The following is a description of a gene set: Human Gene Set: GSE36392_TYPE_2_MYELOID_VS_EOSINOPHIL_IL25_TREATED_LUNG_DN Many symptoms associated with allergic asthma result from the sequelae of type 2 inflammation. Interleukin (IL)-25 promotes type 2 inflammatory responses, and T2M cells represent an IL-4 and IL-13 producing granulocytic IL-25 responsive population. We used microarrays to characterize the gene expression profile of T2M cells, and compared T2M cells to other inflammatory subsets (eosinophils, neutrophils, and macrophages) in the lungs of mice with IL-25-induced pulmonary inflammation. from publication Petersen BC, Budelsky AL, Baptist AP, Schaller MA, Lukacs NW (PMID 22543263) species: Homo sapiens Genes down-regulated in comparison of type 2 myeloid (T2M) cells treated with IL25 versus eosinophils treated with IL25., and this is the list of marker genes: ANKRD37, GGT5, BMX, PDLIM5, DMBT1 (NCBI Gene Id 55583, deleted in malignant brain tumors 1), CNR2, PLA1A, LCN2, SP4, NT5E, TNRC6B, YPEL3, CLK1, GLRX, IL23A, GADD45B, MACROD2, ADGB (androglobin), MED14, ZNF473, CD274, ADTRP, UBE2H, NEK6, AMER2, C18orf32, SLC15A3, RLF, PIGV, PHF23, S100A8, MAPK13, UBA1, NLRP12, MUC16, IL1RAPL1, FMNL3, SOAT2, NXPE3, C15orf48, GMPR2, IRF9, NFIL3, ETS2, STAMBPL1, ENTPD1, MINDY3, GRIN3A, CD300C, GSPT2, LYPD6B, CPED1, SNX18, SLCO3A1, IL18RAP, PDE7B, HSH2D, CDS2, KCTD11, SNORD89, FBXO28, CDC42EP4, PICALM, ENTPD3, RNF135, NDEL1, KDM7A, CYP3A7, MIEN1, SLA, CXCL11, PIPOX, DYNLT2B, TNFSF14, GTF2E2, IFIT1B, HCAR2, CAPS2, DGAT2, ASTE1, HDC, HGSNAT, GSDME, ISG15, PTGER2, AGPAT2, SLC35A5, PLP2, DHX8, SEMA5B, SH2D5, CD300LD, RALGPS1, TNFRSF1B, HMGCL, SFXN5, ATG9A, LRRC3, LYRM4, SDR39U1, CLEC4D, SYCP2, IKBKE, TRMT1L, LRRC72, SAG, SVIP, SIRT2, CALHM6, SNX33, FKBP5, CDK17, MCL1, GK, GPCPD1, MED13L, IL12A, GPAT3, TUT7, HLA-DOB, PABIR1, HERC6, ITIH4, TMEM243, SUGT1, CACNA1E, KCTD8, G3BP2, CHAC1, HSD11B1, CARM1, PTPRC, PRPS1L1, JAK2, GAD1, SAXO4, PCBD2, SLC36A3, SLC25A44, TULP1, MED12L, IFIT3, PIWIL2, PXK, IGF1R (NCBI Gene Id 51049), THAP6, SKIL, IFNLR1, PAG1, TLR6, UBAC2 (NCBI Gene Id 94902), FFAR2, SNAI1, TGM1, CCDC146, PLEKHF2, MTUS1, N4BP1, EEA1, ATG16L1, GCH1, RNF144A, LENG1, TNFSF13B, MTF1, MED20 (NCBI Gene Id 9477), SELENON, IFNGR1, PXYLP1, PPP1R2P1, ATP1B4, ISG20, SH2B2, CREB1, KATNA1, CMTM6, POLR2A, IRAK2, SCRG1, PPP2R2A, MCEMP1, LHX1, NADK, TNF, FLI1, ZNF608, RPRD1B, IFNGR2, TMEM202, TRIM5, BCL2L11, ITGAL, CCDC117, FAM234B, IL18R1, ACOD1, STX11, IFIT1, ADNP2, OTULINL